Given this list of marker genes TLE3, CDC40, GTF2A1, NPIPB3, SF1, IFRD1, SRP19, MAP2K4, SLC6A8, BRAF, ZNF443, RRAGD, MATCAP2, TRAF6, PLAGL2, CGRRF1, STAM2, HAUS3, LINC00869, TNFRSF17, MEF2D, RORA, TERF1, NEFH, TDG, PHACTR4, XAF1, BTRC, MFAP3L, IFI44L, FBP1, PLSCR1, CERNA1, ZNF273, AGTR1, REL, RBM38, CHEK2, ZNF37A, ABCB1, CXCL8, NEFM, RNF19B, SNRK, IL17RA, OLFM1, ZNF391, ITGA2, DFFB, GNA12, BTN2A1, BMP2, EDRF1, MIR9-1HG, MPHOSPH8, PIM2, ZBTB5, SLC12A2, CAMTA1, TGFBRAP1, RNF40, PPAT, POLR2C, STX11, IFI44, ALDH3B2, ARRB2, B4GALT5, PML, HOMER1, TAP1, IGFBP2, MAP3K13, CCDC86, MTF1, WDR82, HTR3A, TESK2, ZFY, CCK, GPD2, RXRB, RAB5C, CFDP1, CYTH1, OAS2, HS3ST1, TLR2, PRORP (NCBI Gene Id 9692), FUT3, TRIM21, GK, ASNS, THEMIS2, LZTS3, ZBTB43, SYNM, DLG1, STIP1 (stress induced phosphoprotein 1), SALL1, AHCTF1, GP1BB, AUTS2, TMEM265, ZBTB18, ZNF184, NPTX2 (neuronal pentraxin 2), PITX2, ZNF263, FEN1, LIN37, ARK2N, here is a description of the gene set: Genes up-regulated in primary fibroblast cell culture after infection with HCMV (AD169 strain) at 12 h time point that were not up-regulated at the previous time point, 10 h. from publication Browne EP, Wing B, Coleman D, Shenk T (PMID 11711622) The effect of human cytomegalovirus (HCMV) infection on cellular mRNA accumulation was analyzed by gene chip technology. During a 48-h time course after infection of human diploid fibroblasts, 1,425 cellular mRNAs were found to be up-regulated or down-regulated by threefold or greater in at least two consecutive time points. Several classes of genes were prominently affected, including interferon response genes, cell cycle regulators, apoptosis regulators, inflammatory pathway genes, and immune regulators. The number of mRNAs that were up-regulated or down-regulated were roughly equal over the complete time course. However, for the first 8 h after infection, the number of up-regulated mRNAs was significantly less than the number of down-regulated mRNAs. By analyzing the mRNA expression profile of cells infected in the presence of cycloheximide, it was found that a minimum of 25 mRNAs were modulated by HCMV in the absence of protein synthesis. These included mRNAs encoded by a small number of interferon-responsive genes, as well as beta interferon itself. Cellular mRNA levels in cytomegalovirus-infected cells were compared to the levels in cells infected with UV-inactivated virus. The inactivated virus caused the up-regulation of a much greater number of mRNAs, many of which encoded proteins with antiviral roles, such as interferon-responsive genes and proinflammatory cytokines. These data argue that one or more newly synthesized viral gene products block the induction of antiviral pathways that are triggered by HCMV binding and entry. studied in species Homo sapiens Human Gene Set: BROWNE_HCMV_INFECTION_12HR_UP